Given this list of marker genes Edem2, Eif2ak3, Man1b1, Rhbdd1, Fbxo6 (NCBI Gene Id 99978), Asgr2, Herpud1, Syvn1, Sec61bl, Derl1, Edem1, Sec61b, Canx, Edem3, Calr, Ern2, here is a description of the gene set: A subcompartment of the endoplasmic reticulum in which proteins with improper or incorrect folding accumulate. Enzymes in this compartment direct proteins with major folding problems to translocation to the cytosol and degradation, and proteins with minor folding problems to the ER, to interact with chaperon proteins. studied in species Mus musculus Mouse Gene Set: GOCC_ENDOPLASMIC_RETICULUM_QUALITY_CONTROL_COMPARTMENT